The following is a description of a gene set: Pathway Definition from KEGG: AURKA -- (TACC3+ch-TOG) -> (TACC3+ch-TOG) == microtubule -> clathrin == (TACC3+ch-TOG) == microtubule studied in species Homo sapiens Kinetochore fiber organization. Pathway ID: N01547. Pathway type: Reference. Pathway class: nt06515 Regulation of kinetochore-microtubule interactions. Human Gene Set: KEGG_MEDICUS_REFERENCE_KINETOCHORE_FIBER_ORGANIZATION, and this is the list of marker genes: CKAP5, TUBA3C, TUBB6, TUBA1A, TUBA4A, TUBA8, TUBB4B, CLTC, TUBA3D, CLTB, TUBB4A, TUBB1, TUBB2A, TUBA1C, TUBA3E, TUBB8, TUBB2B, AURKA, TUBB3, TUBA1B, TACC3, CLTA, TUBB